Given this list of marker genes Mthfr, Hp1bp3, Setdb2, Dmrtc2, Prdm16, H3f4, Snai1, Loxl2, Setd7, Ubr5, Trip12, Mecom, Setdb1, here is a description of the gene set: studied in species Mus musculus Any process that results in the specification, formation or maintenance of the physical structure of eukaryotic heterochromatin, a compact and highly condensed form of chromatin. Mouse Gene Set: GOBP_HETEROCHROMATIN_ORGANIZATION